The following is a description of a gene set: studied in species Homo sapiens Neighborhood of DAP3 Human Gene Set: GNF2_DAP3 Neighborhood of DAP3 death associated protein 3 in the GNF2 expression compendium, and this is the list of marker genes: RPL3, COMMD3, PTBP1, RPSA, HNRNPR, RPL37, ATP5PB, FBL, SRSF2 (serine and arginine rich splicing factor 2), SLC7A5P1, DDX46, PPP1R8, EIF3L, RPS23, SRRM1, EIF3D, DDX21, EXOSC8, EPRS1, RPL4, RPL23A, RPL9, SRSF3, ATP5MC2, RPS16, PAPOLA, SRSF7, RPL37A, KARS1, RPS8, RPL5, KHDRBS1, RPL41, GDI2, MAPK1IP1L, CNOT7, ATP5MG, RPL35A, INTS8, GTF3A, PSMA1, UTP3, RPL12, RPS29, RTRAF, ABCB7, HNRNPU, RPL24, SUMO2, HNRNPC, CPSF6, LSM8 (LSM8 homolog, U6 small nuclear RNA associated), RPL27A, HDAC1, PSMA7, HSPA14, RPL7A, RPL23, RPL27, ZNF207, MAGOH, BTF3, RWDD1, RPS17 (NCBI Gene Id 6218), PSMB1, TARDBP, EIF3E, SRP72, SNRNP200, RBMX, RBM15, PRICKLE4, TMA7, RPL6, DDX50, PPP6C, SNRPE, RPS28, RPL19, SRP19, IFRD1, DAP3, RPS3A, ATG5 (NCBI Gene Id 9474), RPS3, DDX39B, DHX15, NOL11, RPL32, UXT, EIF3K, PSMD13, COX7C, HNRNPA1, SRSF1, UBA52, PPIH, NACA, PPIA, RPL17, TRA2B, PNRC2, RPS2, RPL39, RPL13A, RPS6, RPL38, SNRPD3, RPL7, RPS24, CCDC59, RPL31, PTMA, RPL14, RNF138, NSA2, RPL22, RPS7, CDV3